Given this list of marker genes Mtcl2, Kdm5c, Erv3, Zmiz1, Inpp5f, Slc22a1, Rabgap1 (NCBI Gene Id 227800), Hrh2, Gpr157, Ttc28, Rcc2, Src, Pkdcc, Spmap2l, Wnt7a, Slc37a1, Prss30, Aim2, Kctd15, Gnb1l, Dnajc11, Gpr50, Rnf220, 1810010H24Rik, Heyl, Olfml3, Atp2b2, Lrrc23, Dmbt1, Hs3st5, Nans, Pacsin1, Cxcr2, Chrm1, Pde4b, Crppa, Draxin, Hemk1, Prrg3, Asb11, Nr2c2, Cd200r2, Plekhs1, Tppp3, Nudt10, Stpg1, Inpp5e, Zfp976, Wbp1l, Sigmar1, Hdgf, Ddi2, Trim62, Reep6, Rnf151, Mettl9, Caln1, Gdi2 (NCBI Gene Id 14569), Notch2, Sirt2, Slc25a23, Heatr6, Phlpp1, Csrnp3, Sox12, Igbp1b, Syne1, Sfxn4, Scn3b, Tmem198b, Gm9, Smad6, Fzd8, Smg6, Spring1, Urah, Atp8b5, Eif2ak2, Ubxn10, here is a description of the gene set: species: Mus musculus from publication Chen Y, Wang X (PMID 31504780) Mouse Gene Set: MIR_3075_5P Genes predicted to be targets of miRBase v22 microRNA mmu_miR_3075_5p in miRDB v6.0 with MirTarget v4 prediction scores > 80 (high confidence targets).